The following is a description of a gene set: from publication He P, Lim K, Sun D, Pett JP, Jeng Q, Polanski K, Dong Z, Bolt L, Richardson L, Mamanova L, Dabrowska M, Wilbrey-Clark A, Madissoon E, Tuong ZK, Dann E, Suo C, Goh I, Yoshida M, Nikolić MZ, Janes SM, He X, Barker RA, Teichmann SA, Marioni JC, Meyer KB, Rawlins EL (PMID 36493756) GMP species: Homo sapiens Human Gene Set: HE_LIM_SUN_FETAL_LUNG_C2_GMP_CELL, and this is the list of marker genes: ELANE, RNASE3, CTSG, TRGC1, MTARC1, SLC43A1, MS4A3, PCLAF, C1QTNF4, TOP1MT, HERC5, FKBP11, PRTN3, KCNE5, ARMH1, CLEC11A (NCBI Gene Id 9944), FUT4, NUCB2, MPO, MGST1, CITED4, CST7, MYB, DEFA4, MCM6 (minichromosome maintenance complex component 6), ERLIN1, AZU1, RGL4, DEFB1, SERPINB10, TSPOAP1, RAB44, DDX11, PRSS57, NKG7, MEG3 (maternally expressed 3), MLC1, HGF, RNASE2, C16orf74, SERPINB8